Given this list of marker genes FCGR3A, IGKV2-28, IGLV11-55, IGLV1-40, IGHV1-2, FCGR1A, PRKAR2B, IGKV1-5, IGKV1-39, GNAZ, IGKV2D-30, ITPR2, IGKV2D-28 (immunoglobulin kappa variable 2D-28), ADCY2, GNB3, GGT5, PRKX, GNG13, PRKAR2A (protein kinase cAMP-dependent type II regulatory subunit alpha), IGHV4-39, IGKV3D-20, IL10, DPEP2, GNG3, IGKV1-16, IGLV3-16, IGKV1D-33, PLCG1, IGKV5-2, SYK, PRKACG, GNGT1, YES1, IGKV1-17, GNG12, AHCYL1, IGHV2-70, IGHV, IGKV3-20, IGLV10-54, IGLV6-57, IL6, IGKV2D-40, GNB5, IGLV4-3, IGLV2-14, IGLV8-61, PLK2, IGHV2-5, IGHV1-69, IGKV3-15, MYH9, GNGT2, ADORA2B, IGLV2-11, ADCY8, IGKC (NCBI Gene Id 3514), FYN, LYN, DPEP1, IGLV7-46, IGHV3-30, IGHV3-13, IGHG3, IGHV3-33, CYSLTR1, IGHV1-46, IGLV3-25, IGLV2-18, IGLV2-8, IGLV, IGLV3-21, PRKAR1B, IGHV4-34, IGHG1, ITPR3, GNG7, ADCY6, IGLV3-1, GNG8, IGKV1-33, IGLC7, IGKV1D-39, RHBDF2, IGLV3-12, ADAM17, IGHV3-11, GNG4, IGLC1 (immunoglobulin lambda constant 1), IGLV1-51, GNG2, IGLV3-19, ADCY9, IGHG2, IGKV2-29, CALM1, IGLV4-60, IGLV1-47, ITPR1, HCK, CD163, IGLV2-33, GNAS, GNG10, IGLC3, FCGR2A, GNB1, IGKV4-1 (immunoglobulin kappa variable 4-1), ADCY5, CREB1, PRKAR1A, GNAI2, SRC, GNAI3, CD3G, PLCG2, GNG11, FURIN, IGLV5-37, IGKV1D-16, GNG5, IGKV1D-12, GNAI1, IGHV3-48, GGT1, IGLV3-22, PRKACB, IGLC2, IGHG4, ADCY4, MAPK14, IGLV1-36, IGKV1-12 (NCBI Gene Id 28940), ADCY1, IGLV3-27, IGHV4-59, IGLV7-43, CD247, IGLV4-69, IGKV2-30, GNAT3, LPG1G2, IGHV3-53, IGKV3-11, IGLV5-45, IGLV2-23, CYSLTR2, IGLC6, IGHV7-81, IGHV3-23, PRKACA, IGLV1-44, GNB2, FGR, GNB4, IGHV3-7, ADCY3, ADCY7, IGHV3-9, here is a description of the gene set: studied in species Homo sapiens part of: Leishmania parasite growth and survival Macrophages specializing in tissue repair or associated with a Th2-type immune response are more permissive to infection with leishmania, since their defense mechanisms are not very efficient in eliminating the parasite and can contribute to its persistence. Reactome Pathway: Anti-inflammatory response favouring Leishmania parasite infection